The following is a description of a gene set: Mouse Gene Set: GOBP_HEMIDESMOSOME_ASSEMBLY species: Mus musculus Assembly of hemidesmosomes, integrin-containing protein complexes that bind to laminin in the basal lamina. Hemidesmosomes form the contact between the basal surface of epithelial cells and the underlying basal lamina., and this is the list of marker genes: Itgb4, Lama3, Col17a1, Lamc1, Plec, Dst